Given this list of marker genes CTSC, SURF1, LYZ, TST, PSMB9, VAMP8, NSA2, NFE2L3, TSPAN8, SLC1A1, SMIM11, HIBADH, OVGP1, CAVIN2, GSTO1, NUDT4, ELF3, ITCH, THRSP, MNAT1, EMB (embigin), EMP1, PFDN2, FAM3C, MDFIC, PAX8, NCBP2AS2, LGALS3, TMOD3, ANPEP, ISG15, SDCBP (NCBI Gene Id 6386, syndecan binding protein), IFIT1B, RNASET2, S100A13, PLA2G4A, CBR1, LXN, EIF3E, RAB25, IMMP1L, HES1, SUGT1 (NCBI Gene Id 10910), RHPN2, TMX2, A4GALT, CHCHD10, MAN1B1, DBNDD2, H2AZ2, TMPRSS2, EYA2, H2AC18, AHR, CD53, CD24, PRKAB1, AKTIP, CD83, PON2, RPL36AL, DLX6, RTCB, HLA-B, IRF7, IGLV2-18, PPM1B, PKP4, CASP1, FAAP20, FXYD3, TYROBP, IRF9, UPK3B, TES, KRT19, PSMB8 (NCBI Gene Id 5696), MARCKS, NFIB, here is a description of the gene set: Human infertility and recurrent pregnancy loss caused by implantation defects are poorly understood. Hoxa-10-deficient female mice have severe infertility and recurrent pregnancy loss due to defective uterine implantation. Gene expression profiling experiments reveal that Hoxa-10 is an important regulator of two critical events in implantation: stromal cell proliferation and local immunosuppression. At the time of implantation, Hoxa-10 mediates the progesterone-stimulated proliferation of uterine stromal cells. Hoxa-10 mutants express a stromal cell proliferation defect that is accompanied by quantitative or spatial alterations in the expression of two cyclin-dependent kinase inhibitor genes, p57 and p15. Hoxa-10 deficiency also leads to a severe local immunological disturbance, characterized by a polyclonal proliferation of T cells, that occurs in place of the normal progesterone-mediated immunosuppression in the periimplantation uterus. Genes co-regulated in uterus during a time course response to progesterone: SOM cluster 9. from publication Yao MW, Lim H, Schust DJ, Choe SE, Farago A, Ding Y, Michaud S, Church GM, Maas RL (PMID 12554760) Human Gene Set: YAO_TEMPORAL_RESPONSE_TO_PROGESTERONE_CLUSTER_9 species: Mus musculus